Given this list of marker genes WDR90, MTHFD1L, ZNHIT1, ALDOA, APOO, HPSE, PLK1, CHSY1 (NCBI Gene Id 22856), AP2M1, SEPTIN11, DHRS4 (NCBI Gene Id 10901), THOC3, MRPL20, CRYBG2, DPP3, ETFB, TIMM23, SHCBP1, C18orf21 (NCBI Gene Id 83608), PLCB4, CDK4, CYB5R3, CHTF18, ODR4, PSMA2, RRM2, TSPAN2, ARPC4, LRR1, UBE2S, TTC39C, ACAA2, PLK4, GMPPA, RFWD3, ATP5MC3, SKA1, ITGAL, LCMT1, GTF2F2, DNMT1, RYK, DDX1, ORC2, MRPL54, PSMD13, EI24, RAD51, CHAF1B, MRPL33, TBC1D4 (NCBI Gene Id 9882), UHRF1, FKBP1A, SLCO4A1, NDUFB2, NRM, WASHC5, CDC34, PNO1, HPF1, MKI67, GTSE1, SAE1, COPZ1, SLC37A2, TMED1, R3HCC1, ENKD1, ANAPC15, COPS4, C11orf71, NDUFA8, SLC12A2, CDKN2C, CENPF, EBI3, BLM, HAUS4, CTC1, RAB19, UCHL5, MTRES1, LRRC40, NCAPH2, PRELID3B, ENO1, PRORP, DNAJC3, FBXO27, TNFRSF8, BCL2A1, TINF2, ANXA2, ASF1B, PTPN3, DPCD, RRM1, POLD3, PDCD1LG2, MED8, LITAF, PPP2R3C, NUF2, TOMM40, EIF2B5, CENPH, CNTROB, USP1, ATPAF2 (ATP synthase mitochondrial F1 complex assembly factor 2), PPP5C, TIMM22, AKIP1, TOP2A, RAD54L, GRN (NCBI Gene Id 2896), MED9, TIMP2, CNTLN, LZTFL1, NEK6, ESPL1, DGCR6, EME1, OXGR1, STIL, ABCB9, GPI, TMEM160, MRPL18, PIDD1, TPX2, IFNG, MRPL11, ALCAM, RNASEH2B, GMDS, SDR39U1, SSR2, PASK, KIF3A, HMGB3, KIF11, IMPDH2, MRE11 (MRE11 homolog, double strand break repair nuclease), NCAPG, PPFIBP1, ARL1 (ADP ribosylation factor like GTPase 1), EIF1AX, SPCS3, SLC25A4, CKAP2, MAST2, CCNA2, COPS3, MZT2B, PXN, FAM98B, PDAP1, GALK1, CHEK1, DNAJC2, KIF22, COX7A2, POGLUT3, PTTG1, CHEK2, EXOSC2, CST7, CENPS, ASNSD1, RAVER1, SMTN, LYSMD2, ITPK1, MYL4, ZCCHC3, LRWD1, LAG3, H1-0, VPS36, AARS1, TRAPPC5, BLMH, NOL7, ICOS, CAV3, PPP1R7 (protein phosphatase 1 regulatory subunit 7), TP53I13, PRMT6, PSMD1, PENK, UBE2V1, CCNE1 (cyclin E1), PALS2, UQCRQ, PABPC1, ZNF518B, H2AX, SNF8, MRPL57, here is a description of the gene set: Human Gene Set: GSE43863_TH1_VS_LY6C_LOW_CXCR5NEG_EFFECTOR_CD4_TCELL_UP studied in species Homo sapiens Genes up-regulated in CD4 SMARTA effector T cells during acute infection of LCMV: Th1 versus Ly6c low CXCR5-. from publication Hale JS, Youngblood B, Latner DR, Mohammed AU, Ye L, Akondy RS, Wu T, Iyer SS, Ahmed R (PMID 23583644) CD4 T follicular helper (Tfh) cells provide the required signals to B cells for germinal center reactions that are necessary for longlived antibody responses. However, it remains unclear whether there are CD4+ memory T cells committed to the Tfh lineage after antigen clearance. Using adoptive transfer of antigen-specific memory CD4+ subpopulations (based on CXCR5 and Ly6c expression)in the LCMV infection model, we found that there are distinct memory CD4+ T cell populations with commitment to the Tfh and Th1 lineages. Our conclusions are based on gene expression profiles, epigenetic studies and phenotypic and functional analysis. The gene expression profiles of virus-specific CD4 T cell subets at effector and memory stages is presented here.